The following is a description of a gene set: species: Mus musculus Genes predicted to be targets of miRBase v22 microRNA mmu_miR_129b_3p in miRDB v6.0 with MirTarget v4 prediction scores > 80 (high confidence targets). from publication Chen Y, Wang X (PMID 31504780) Mouse Gene Set: MIR_129B_3P, and this is the list of marker genes: Cyria, Cdan1, Cyp4a12a, St13, Fndc10, Ikzf3, Bmp3, Slc6a2, Fam53c (family with sequence similarity 53, member C), C1qbp, Pcdh17, Psd3, Hlcs, Pigq, Ndel1, Gpm6b, Pml, Abcd3, Efna5, Dusp6, Ddx5, Kcnd3, Tnrc6a, Fbxo32 (F-box protein 32), Amd2, Krtap9-22, Gm8369, Mink1, Bcl9, Kcns3, Pdc, Pigm, Ctnnd1, Mdga2, Fcrl5, Pcbp4, Togaram1, Kpna3, Cyp4a12b, Abcg1, Bpi, Sh3rf1, Ncoa2